The following is a description of a gene set: A class of nuclear body; they react against SP100 auto-antibodies (PML, promyelocytic leukemia); cells typically contain 10-30 PML bodies per nucleus; alterations in the localization of PML bodies occurs after viral infection. Human Gene Set: GOCC_PML_BODY species: Homo sapiens, and this is the list of marker genes: ZBTB16, RGS14, CIART, EIF3E, TP53INP1, NFE2, ATR, UBN1, CIITA, SMC5, SP100, RB1, TDG (thymine DNA glycosylase), TOPBP1 (NCBI Gene Id 11073), TOPORS, CDK9 (cyclin dependent kinase 9), SKIL, RNF111, RNF4, THAP1, EIF4ENIF1, HIPK2, ELF4, PIAS1, BASP1, RDM1, CHFR, TCF7L2, PATL1, DAPK3 (death associated protein kinase 3), CHD3, ISG20, PML, SIRT1, SQSTM1, SRSF2, RAD51, SP140, RNF6, MTOR, MORC3, TERT, SLF2, BMAL1, SENP2, SUMO2, HIPK3, RFWD3, MKNK2, TRIM16, NR2C1, NSMCE2, SP3, TDP2, PPARGC1A, CBX5, PIAS2, SUMO3, DAXX, MRE11, TENM2, MAPK7, SPTBN4, IKBKE, ZMYM2, CSNK2A1, CHEK2, MAGEA2B, HIPK1, RPAIN, UBE2I, MAGEA2, ATRX, SPN, SIMC1, SMC6 (structural maintenance of chromosomes 6), TRIM8, TRIM27, MLIP, ANKRD2, TP53INP2, RPA1, PTEN, CSNK2B (NCBI Gene Id 257616), NBN, N4BP1, SUMO1, PARK7, TP53, HSF1, TOP3A, HMBOX1, AKAP8L, GCNA (germ cell nuclear acidic peptidase), LRCH4, KAT6A, ZNF451, HIRA, KLHL20, RPA2, CALCOCO2, ZBED1, SATB1, USP7, PIAS4, BLM, CASP8AP2, WDFY3, SKI, SUMO1P1